Given this list of marker genes SRGAP2, PPP1R9B, GPER1, NRGN, RGS7BP, HPCA, here is a description of the gene set: species: Homo sapiens Human Gene Set: GOCC_DENDRITIC_SPINE_HEAD Distal part of the dendritic spine, that carries the post-synaptic density.